The following is a description of a gene set: The process in which a relatively unspecialized cell acquires specialized features of a pacemaker cell. Pacemaker cells are specialized cardiomyocytes that are responsible for regulating the timing of heart contractions. studied in species Mus musculus Mouse Gene Set: GOBP_CARDIAC_PACEMAKER_CELL_DIFFERENTIATION, and this is the list of marker genes: Tbx3, Isl1, Tbx18, Popdc2, Kcnj8, Maml1, Bves, Mesp1, Nkx2-5, Bmpr1a, Shox2, Tbx5